Given this list of marker genes WDFY1, IDH3G, RMND5B, CXCL12, DNAJB11 (DnaJ heat shock protein family (Hsp40) member B11), GLUD1, ANGPTL2 (angiopoietin like 2), GYG1, MOCS2, LINC01160, FIZ1, ZSCAN25, ZNF592, TRIO, RMI2, SMIM7, ZNF449, DUSP22, TUBGCP4, FNIP2, SMC1A, HADH, TBC1D2, MYO6, FAM76A, SLC39A10, WDR41, IBA57, RAD50, ZNF436, IDUA, MMP19, USF2, UXS1, HMBS, LHFPL2, MED7, PPP1CA, GOLPH3, UHMK1, PPP1R8, FRRS1, NLK, LACTBL1, TGFA, CENPN, NCOA3, DMAC2L, FOXM1, CAPN2, GPR137B, HS1BP3, DNA2, ZSCAN10, LANCL2, RGS7BP, PPFIA1, GDAP2, LCMT2, EFR3A, SIAH2, SLC18B1, EIF3B (NCBI Gene Id 8662), MEIOC, FAM120A, MFAP1, RFNG, PTPN21, FANCD2 (NCBI Gene Id 2177), ZNF318, TMEM178A, FASTK (Fas activated serine/threonine kinase), GET4, ITPR2, TRIR, RXRA, WDR35, PDXK, PAQR4, IDH3B, MYO1E, RAB14, TUBA4A, RDH13, APOBEC1, ZCCHC2, PACC1, VWA5A, STRN (striatin), SMG7, PLPBP, SLC38A9, LRP1, CPT2, CBLL1, ABCB6, DPP9, RAB3GAP2, UMPS, GMNN, APOBR, ATP1B3, STRAP, COA5, OSBPL5, HIP1, CREB3, PKP4, LGALS1, NDUFA9, ZIK1, MECOM, B4GALT5, ELAVL1, ZSWIM8, TFAP4, SFT2D3, PLIN3, TCF19, PPP1R12C, PARPBP, VIM, RABL3, SKIC3, TONSL, PARP1 (NCBI Gene Id 142), ANPEP, GSDME, NKTR, CENPA (centromere protein A), ARHGEF1, RAB1A, VPS29, GASK1B, MRPL22, RPS6KC1, TTC3, TBL1XR1, DEPDC1B, TM9SF4, TMEM87A, TSPAN5, DOCK2, STAC2, TEX261, MOCOS, ZNRF3, STOML3, SGTB, FLRT2, LATS1, UNG (uracil DNA glycosylase), LRRC8A, OTUB1, AP2M1, TTL, RASAL2, BBS7, PRKCB, LRFN4, CPNE2, ASTE1, WDR13, NPY, CDC42BPB, TGIF1, ATP8A1, AHCYL2, BCAP29, GDF3, ZMYM4, BTBD9, NT5C2, SPDL1, ZC3HAV1, DAAM1 (dishevelled associated activator of morphogenesis 1), LRIG1, ETFRF1, MED12, CNOT4, FANCG, LSM12, RAB3IL1, KIAA1958, KLF13, CD27, MAN1C1, MYO7A, UNC13B, RNF10, ALG3, PSMB7, MKRN2, PAIP1, PRKD3, TFCP2, TMEM41A, PRPF8, AMZ1, CTNNBIP1, here is a description of the gene set: from publication Derbinski J, Gäbler J, Brors B, Tierling S, Jonnakuty S, Hergenhahn M, Peltonen L, Walter J, Kyewski B (PMID 15983066) Gene expression in different thymic stromal cells and subsets thereof was analyzed in 6-12 week old wild type (C57BL/6) and Aire knock-out (mixed background) mice. Thymic stromal cells were purified by sequential enzymatic digestion (collagenase, collagenase/dispase and trypsin) followed by gradient centrifugation and FACS sorting. Sort criteria were as follows: dendritic cells (CD11c+, F4/80 -), macrophages (F4/80+, CD11c-), cTECs (CD45–/lo, CDR1/Ly51+, Ep-CAM+) and mTECs (CD45–/lo, CDR1/Ly51–, Ep-CAM+). mTECs of wild-type and Aire knock-out mice were further subdivided according to CD80 expression levels. For microarray analysis total RNA from thymic stromal cell samples of two independent experiments was pre-amplified and biotinylated by two rounds of cDNA synthesis and in vitro transcription. Fluorescence readings were evaluated by using Microarray Suite 5.0 software. species: Homo sapiens Human Gene Set: GSE2585_AIRE_KO_VS_WT_CD80_HIGH_MTEC_UP Genes up-regulated in medullary thymic epithelial cells (mTEC) with CD80 high: AIRE knockout versus wildtype.